The following is a description of a gene set: Genes down-regulated in comparison of mast cells versus dendritic cells (DC). from publication Jeffrey KL, Brummer T, Rolph MS, Liu SM, Callejas NA, Grumont RJ, Gillieron C, Mackay F, Grey S, Camps M, Rommel C, Gerondakis SD, Mackay CR (PMID 16474395) studied in species Homo sapiens In the present study we used Affymetrix oligonucleotide microarrays to produce gene transcription profiles for the major leukocyte types in humans. This comprehensive dataset enabled us to not only establish which genes were expressed in each leukocyte type, but also which genes were expressed in each subset after activation. The used of a comprehensive dataset of gene profiles from all the major human leukocyte subsets enabled a novel and powerful means for identification of genes associated with single leukocyte subsets, or different immune paradigms. Human Gene Set: GSE3982_MAST_CELL_VS_DC_DN, and this is the list of marker genes: RPP25, IL13RA1, MYOF, PEX19, DUSP2, CTTN, NUDT13, IL1R2, HIVEP3, EPCAM, ADAM10 (ADAM metallopeptidase domain 10, NCBI Gene Id 102), DCSTAMP, KLHL22, C1orf115, SLAMF8, ITPKB, DDO, GPT, ANXA2P1, GTF3C5, PSEN2, REX1BD, GUCA1A, RAB31, HLA-DRA, FCHSD2, CTSH, H3C1, DNPEP, ACADSB, SNX13, CXCR2, IL15, CA2, RAMP1, ALCAM, FBXO21, TPD52, FCER2, SDC2, CCR5, PRDX3, SCARB1, GH1, TRIM14, ASPHD1, PLXNB2, KIR2DL2, MAPK1 (NCBI Gene Id 5594), TACSTD2, PTPRA, AKR7A2, SPP1, ANKRD11, SYNGR1, CD1E, KIF1B, PRKAR2B, GALNT12, SFT2D2, GPD1, DOC2B, IQSEC2, ANXA11, DNAJC10, CCL22, HPCAL1, MDH1, SORT1 (NCBI Gene Id 6272), CDS2, NANS, ACOX1, SDC4, SHFL, CCDC106, SCAF11, LAMP3, NPR1, ATF3, FPR3, LPAR1, ZNF706, NTN3, MTMR1, SNX27, CYB5A, SLC1A4, HFE, CARD9, KCNQ1DN (KCNQ1 downstream neighbor), IL9, CCL1, KMO, IL10RA, GASK1B, NPC1, NFKBIE, MCUR1, EVC, ABCB4, RHEB, SCPEP1, SYK, LRRFIP2, SEMA6A, ARMCX1, ADIRF, HLA-DMB, FN1, ANPEP, PLEKHS1, TSPAN9, HK3, KLF8, MYOM2, INF2, MCOLN3 (NCBI Gene Id 55283), CSRP2, GNA11, CCNH, RBMS2, RAB23, MLX (NCBI Gene Id 6945), TCIRG1, RGS14, KCNJ1, ULK2, CD36, ACOT7, SLAMF1, SLC31A2, HLA-DQB2, NDOR1, PPP2R3A, LIMA1, RNASE6, HECTD3, RAB20, RASAL2, ORC6, ARSB, TMCC1, SMCO4, VOPP1, KYNU, RAP1GAP, STAT2, CLIP4, SIGLEC7, MPZL1, GAS2L1, COQ8A, LTBR, OTUB2, CKAP4, FSD1, RAB8B, IL1RN, CHST7, TUT7, ACVR2A, CRH, LIPA, RETREG2, CD47, IGF1R, MEP1A, C22orf31, MATK, LIME1, IRF8, RAB11A, CD209, DIAPH2, NUDT9, RIPK4, GUSB (NCBI Gene Id 2990), VASH1, SAMHD1, OAS1, HLA-DMA, HLX, RXRA, CXCL9, AHCYL2, PILRA, MKLN1, GPC1, GTF2IRD1, WNT5B, MYF6, PDLIM4, FA2H (NCBI Gene Id 79152), HSD11B1, CERT1, WIPI1, BARD1, TUBB6, FKBP5